Given this list of marker genes Tyr, Slc45a2, Dct, Tyrp1, Oca2, here is a description of the gene set: part of: Metabolism of amino acids and derivatives electronically inferred by orthology from the curated human pathway This event has been computationally inferred from an event that has been demonstrated in another species.<p>The inference is based on the homology mapping from PANTHER. Briefly, reactions for which all involved PhysicalEntities (in input, output and catalyst) have a mapped orthologue/paralogue (for complexes at least 75% of components must have a mapping) are inferred to the other species. Reactome Pathway: Melanin biosynthesis studied in species Mus musculus